Given this list of marker genes ADAMTS10, MAP2K1, TGFBR2, TWIST1, SMAD4, SETBP1, MYLK, DIS3L2, COPB1, GNE, GIPC1, SCARF2, ORC4, TBX1, ASXL1, EFEMP1, SMG9, PIGA, RPS6KA3, TRPS1, DVL1, SPTBN1, ABCC6, AARS1, RNU4-2, BBS1, ERCC2, CDC6, TAF1, PEX5, NAA10, WASHC5, VPS13B, ATN1, TGFB2, APC, INTU, NEUROG1, BCR, SMAD2, MADD, ESAM, CRKL, MED12, PTPN11, PRUNE1, EP300, H4C5, PTEN (NCBI Gene Id 8037), KIF26A, KLHL41, ACTA2, TCTN3, KMT2D, OCRL, ZFX, SLC35C1 (solute carrier family 35 member C1), MFAP5, FGFR1, PLOD1, RET, VAC14, SH3BP2, COL11A1, AMER1, FBN1, IL11RA, WNT7A, ERCC3, SIN3A, PRKG1, GRB10, GPC4, WNT5A, GPC3, HNRNPK, PCLO, TAOK1, ASXL3, ORC6, MEGF8, PEX1, RAB18, RUNX2 (NCBI Gene Id 860), ADNP, LRP4, TPM3, SLC25A46, AEBP1 (NCBI Gene Id 165), THSD4, RNF113A, FIG4, MCM3AP, GRIA3, AFF4, NEK9, KANSL1, RARS2, CCDC22, ANTXR1 (NCBI Gene Id 84168), ASCC3, NOTCH2NLC, HERC2, DPYSL5, ELMO2, HECW2, BRAF, SMS, KDM6A, LOX (lysyl oxidase), POR, GMNN, MED12L, HECTD4, TARS1 (NCBI Gene Id 94887), ARL6, FOXP2, MAPK1, SOX5, HRAS, GTF2E2 (general transcription factor IIE subunit 2), INTS11, SLC6A17, GTF2H5, DPM1, BRCA1, RECQL4, SKI, DDX59, SLC25A24, SPTAN1, TBX2, SPRED2, CTSK, VPS35L, TECR (NCBI Gene Id 9524), COL3A1, ROR2, DVL3, BCOR, FZD2, RILPL1, MYH11, BMPR1A, CNTNAP1 (contactin associated protein 1), NEB, SCNM1, PIGT, CCDC28B, ATP7A, ARID2, CNTN1, ERMARD, FLNA, KCNK9, NONO, SPEN (spen family transcriptional repressor), LRP12, HEY2, MUSK, NDUFAF6 (NCBI Gene Id 137682), ERF, MYMX, TBCK, MESD, PIEZO2, NSD1, IPO8, CDT1, FOXE3, FGFR3, ORC1, MARS1, UBE3B, MPLKIP, MAT2A, PCDHGC4, MED25, CREBBP, CDK10, CARS1 (NCBI Gene Id 833), ACTA1, MAP3K7, CDC45, TGFBR1, CPT2, SPRED1, PTDSS1, TBC1D24, FGFR2, APC2, CHD6, NOTCH3, CCBE1, IFT122, COL12A1, SMARCA2, SMAD3, ATP6V1B2, UFC1, TGFB3 (NCBI Gene Id 7043), SLC25A12, ELN, here is a description of the gene set: Human Gene Set: HP_NARROW_PALATE Narrow palate species: Homo sapiens Width of the palate more than 2 SD below the mean (objective) or apparently decreased palatal width (subjective).